The following is a description of a gene set: Any process that results in a change in state or activity of a cell or an organism (in terms of movement, secretion, enzyme production, gene expression, etc.) as a result of an erythropoietin stimulus. Erythropoietin is a glycoprotein hormone that controls erythropoiesis. Human Gene Set: GOBP_RESPONSE_TO_ERYTHROPOIETIN species: Homo sapiens, and this is the list of marker genes: MT2A, JAK2, MT1X, CD40, STAT5B (NCBI Gene Id 6777), RHEX, EPO, EPOR (erythropoietin receptor), KIT, CREB1